Given this list of marker genes AHR, C16orf74, ANKRD44, RPS6KB1, TRPC1, ACTR3, HAPLN1, KCNA4, PTPN4, SEC24D, CAP2, LUC7L3, LRRK1 (leucine rich repeat kinase 1), SLC11A2, DRAM1 (NCBI Gene Id 55332), CLDN23, ZBTB43, TBC1D8B, ATG5, SYTL2, FAM3C, FLRT2, P2RY12, PDE3B, DGKH, PCTP, JAK2, ADAMTS6, QSOX2, NFIA, LEMD3, STOX2, EFTUD2, NIPSNAP3B, CCDC50, TRIM6-TRIM34, HECTD2, SGMS1, TMEM65, WDR26 (NCBI Gene Id 80232), ZSWIM6, ZFC3H1 (zinc finger C3H1-type containing), COPS2, CAST, MITF, LRP5 (NCBI Gene Id 8058), SLAIN2, HIPK2, PREX1, SLC7A11, SLITRK2, SEH1L, LRBA, ACTR2, SMIM3, UTP15, NR1D2, CLEC3A, FAM13A, CSRNP3, ADGRL3, MOSPD3, PHACTR2, ZCCHC14, IFI44, FCHSD2, ACTN4, ANKRD6, PCGF5, AFDN, NRP2, ZFHX3, VAPB, BCL11B, TMED10, LRCH1, ATXN1, STARD4, SLC16A1, TSN, BTBD3, MAP3K9, GABARAPL1, VGLL3, PRLHR, TRIM34, CSNK1A1, ENY2, RNF168, ZNF592, PTBP3, UBXN10, MED6, MTRR, PRPF40A, SNAPC1, FAT1, MRPS27, ATP8A2, TIMM8A, ADD3 (NCBI Gene Id 121), TMOD1 (tropomodulin 1), PCDHGA7, TLCD5, DPYD, POGZ, ZNF843, NSUN4, TMEM132E, TMPRSS11A (transmembrane serine protease 11A), PTGR3, DNAJB11, RBM27, ATE1, FLI1, EBLN2, TMEM170B (NCBI Gene Id 100113407), C2orf49, SLC10A7, NREP, FXYD3, HSD17B11, MTMR8, SCN2B, PPP2R2A, MBTD1, SIX2, TMTC2 (transmembrane O-mannosyltransferase targeting cadherins 2), KDM5B, SOX9, MBD1, G2E3, here is a description of the gene set: species: Homo sapiens Human Gene Set: MIR605_5P Genes predicted to be targets of miRBase v22 microRNA hsa-miR-605-5p in miRDB v6.0 with MirTarget v4 prediction scores > 80 (high confidence targets). from publication Chen Y, Wang X (PMID 31504780)